The following is a description of a gene set: studied in species Homo sapiens Human Gene Set: ZHONG_PFC_C9_ORG_OTHER from publication Zhong S, Zhang S, Fan X, Wu Q, Yan L, Dong J, Zhang H, Li L, Sun L, Pan N, Xu X, Tang F, Zhang J, Qiao J, Wang X (PMID 29539641), and this is the list of marker genes: MGST3, TSPAN7, SEL1L3, SELENOW, NHERF1, LITAF, PEA15, ENHO, PTN, DBI, NRG1, NDN, EEPD1, IFI27L2, ATP1B2, TNC, TUBB2A, MYORG, BCAN, AXL, COL11A1, FABP5, CXCR4, TKTL1, NTM, MLC1, S100A16, MEST, ITGB8, ITM2C, TAGLN2, STOM, ETV5, SNX5, NSDHL, NDRG2, CLU, PDLIM3, NFE2L2, TTYH1, PSAT1, MFGE8, TMEM132B, TSPO, GATM, NDP, PTPRN2, FAM107A, CST3, CRYL1, PDPN (NCBI Gene Id 29912), MOXD1, LRRC3B, OAT, PLPP3, LGALS3, SC5D, F3, SAT1, CDO1, FOLH1, SCRG1, BMP7, ATP1A2, NOTCH2 (notch receptor 2), MT3, FABP7, DKK3, SLC1A3, CDC42EP1, LINC00943, HOPX, ID2, LIFR, TMEM9B, SLCO1C1, PTPRZ1 (NCBI Gene Id 7983), SPARC, S100A13, GPX3, GPM6B, TCIM, GNG12